The following is a description of a gene set: Down-regulated genes discriminating multiple myeloma samples by type of immunoglobulin they produce: IgG vs IgA. from publication Magrangeas F, Nasser V, Avet-Loiseau H, Loriod B, Decaux O, Granjeaud S, Bertucci F, Birnbaum D, Nguyen C, Harousseau JL, Bataille R, Houlgatte R, Minvielle S (PMID 12623842) Human Gene Set: MAGRANGEAS_MULTIPLE_MYELOMA_IGG_VS_IGA_DN studied in species Homo sapiens Although multiple myeloma (MM) is a unique entity, a marked heterogeneity is actually observed among the patients, which has been first related to immunoglobulin (Ig) types and light chain subtypes and more recently to chromosomal abnormalities. To further investigate this genetic heterogeneity, we analyzed gene expression profiles of 92 primary tumors according to their Ig types and light chain subtypes with DNA microarrays. Several clusters of genes involved in various biologic functions such as immune response, cell cycle control, signaling, apoptosis, cell adhesion, and structure significantly discriminated IgA- from IgG-MM. Genes associated with inhibition of differentiation and apoptosis induction were up-regulated while genes associated with immune response, cell cycle control, and apoptosis were down-regulated in IgA-MM. According to the expression of the 61 most discriminating genes, BJ-MM represented a separate subgroup that did not express either the genes characteristic of IgG-MM or those of IgA-MM at a high level. This suggests that transcriptional programs associated to the switch could be maintained up to plasma cell differentiation. Several genes whose products are known to stimulate bone remodeling discriminate between kappa- and lambda-MM. One of these genes, Mip-1alpha, was overexpressed in the kappa subgroup. In addition, we established a strong association (P =.0001) between kappa subgroup expressing high levels of Mip-1alpha and active myeloma bone disease. This study shows that DNA microarrays enable us to perform a molecular dissection of the bioclinical diversity of MM and provide new molecular tools to investigate the pathogenesis of malignant plasma cells., and this is the list of marker genes: CSF3R, TPBG, ITGA2B, IL16 (NCBI Gene Id 3603), IL1B, BRCA1, IGHG1, PELO, CSF1R, GLUD1, KLF1, SEPTIN5, ID2, RAP1A, CFI, CCND1, UBAP2L, ACTB, FBP1, ZNF148, RPL13AP5, CSK, GATA6, DAP, PSMB7, ALAS2, FGB, MYB